Given this list of marker genes MFSD8, RNF14, ARL8B, DLG1, FAM156A, TNKS, EFCAB14, MTMR4, TOR1AIP1, CEP350, PRKAB2, ZZZ3, GOLGA7, GARRE1, ZNF404, WSB1, EIF3J, BPNT2 (3'(2'), 5'-bisphosphate nucleotidase 2), DDHD2, ATRN, FRYL, FBXO45, MAP4K4, AHCYL1, RDX, GORASP1, DYNC1I2, BLTP1, SNX5, IL6ST, ARAP2, ERBIN, RAB10, RASSF3, MTMR2, RAB22A, GOLM2, EHBP1, SCRN3, VPS41, PCNP, WDR11, NAPG, SEC22C, MACF1, TBC1D15, GLTP, ARFGAP1, AIDA, NPTN, ICE1 (NCBI Gene Id 23379), CAB39, OCIAD1, OTUD6B, VPS13B, DICER1, RNF13, FBXW11, BBS2, CRP, TMEM248, ANKFY1, NEK9, FAM168B, AGPAT5, here is a description of the gene set: Neighborhood of ERBB2IP Neighborhood of ERBB2IP erbb2 interacting protein in the GCM expression compendium Human Gene Set: GCM_ERBB2IP species: Homo sapiens